Given this list of marker genes Dynll1, Bbs4, Hap1 (NCBI Gene Id 268486), Septin9, Dnm2, Rp1, Ttbk2, Pqbp1, Htt, Tmem67, Mir129-2, Cenpj, Mak, Atmin, Wrap73, Cep135, here is a description of the gene set: Mouse Gene Set: GOBP_REGULATION_OF_NON_MOTILE_CILIUM_ASSEMBLY Any process that modulates the frequency, rate or extent of non-motile cilium assembly. studied in species Mus musculus